Given this list of marker genes TGIF1, ZNF165, MRPL28, IRF7, DCUN1D2, SNAP91, PRG2, PIM3, STAR, CLK1, PCDHGA8, NR4A1, DIPK1B, EZH2, MIA2, CT83, PMAIP1, MAPK8IP1, MNT, STATH, IFIT3 (interferon induced protein with tetratricopeptide repeats 3), TP53INP2, SUN3, PPP4R1L, WDR19, LINC02112, PMP22, NFAT5, HOMER1, LINC00485, RGS2, ZCCHC14, MZF1-AS1, MYEF2, NOS3, LINC02537, TENT4A, NACA2, NOL12, LARP1B, H4C6, ZC3H8, KDM6B, THSD4, CXCL10, PELI1, LINC-PINT, GNL3L (NCBI Gene Id 54552), HTN3, TP53BP2, DNAJC27, MX1, CCNA1, GJB6, IRAK2, PDE4B, NIPAL1, NFKBID (NFKB inhibitor delta), MEX3B, FOXO3, RNF133, TRAF1, NIPA1, SLC25A33, CREB5, MAFK, ISG15, IFNB1, NR4A2, HCAR3 (hydroxycarboxylic acid receptor 3), IFIT2, TNF, ZC3H12C, MIR155HG, GCKR, EIF2AK3, GFOD1, ERRFI1, POLRMTP1, CSRNP2, OSM, PURB, NEURL3, CCDC134, NEBL-AS1, TBC1D21, CDRT15L2 (NCBI Gene Id 256223), C11orf96, B3GNT5, PTGER4, RNF19A, INSL3, ZNF620, PTGS2, MPZL1, GRIN2B, DNAJB1, CREBRF, CSRNP1, SPMIP1, GEM, CDR1, CLK4, MXD1, FNBP4, USP6NL-AS1, SLC22A4 (solute carrier family 22 member 4), SFRP5, RAB11FIP1, GPR32, SIRT1, FBXO34, RSPH9, TMEM217, RHOB, TPSD1, MAP3K20-AS1, HUS1B, IVNS1ABP, PATL2, FGF9, SSBP3-AS1 (NCBI Gene Id 619518), FAM200A, WFDC3, PCYT1B, SPTBN4, CREM, PLPPR4, CAMKK1, MAK, MIR22HG, GADD45B, EFNB2, ABO, BTBD19, MFAP4, CLCA1, TMEM212, SAMD5, DDX59, CFAP61, ABL2, DUBR, DENND4A (DENN domain containing 4A), NR4A3, CLDN10, HOXB13, PHF13, KBTBD8, GPLD1, MAT2A, IRS2, DRC3, AREG, PPP2R3B, MRGPRX2, PCDHAC2, IRF1, NAMPT (NCBI Gene Id 10135), SLC19A2, SCML1, GK, CREB3L3, RIMKLB, METRNL, DOP1A, TAMALIN, FAM9C, TTC32, ANKRD40CL, CSNK1D, AGAP2 (ArfGAP with GTPase domain, ankyrin repeat and PH domain 2), ZNF157, ZBTB43, KCTD5, ETV3, IFIT1, ZNF711, here is a description of the gene set: Genes down-regulated in comparison of control conventional dendritic cells (cDC) at 0 h versus cDCs infected with Newcastle disease virus (NDV) at 2 h. Human Gene Set: GSE18791_CTRL_VS_NEWCASTLE_VIRUS_DC_2H_DN from publication Zaslavsky E, Hershberg U, Seto J, Pham AM, Marquez S, Duke JL, Wetmur JG, Tenoever BR, Sealfon SC, Kleinstein SH (PMID 20164420) studied in species Homo sapiens The dendritic cell (DC) is a master regulator of immune responses. Pathogenic viruses subvert normal immune function in DCs through the expression of immune antagonists. Understanding how these antagonists interact with the host immune system requires knowledge of the underlying genetic regulatory network that operates during an uninhibited antiviral response. In order to isolate and identify this network, we studied DCs infected with Newcastle Disease Virus (NDV), which is able to stimulate innate immunity and DC maturation through activation of RIG-I signaling, but lacks the ability to evade the human interferon response. To analyze this experimental model, we developed a new approach integrating genome-wide expression kinetics and time-dependent promoter analysis. We found that the genetic program underlying the antiviral cell state transition during the first 18-hours post-infection could be explained by a single regulatory network. Gene expression changes were driven by a step-wise multi-factor cascading control mechanism, where the specific transcription factors controlling expression changed over time. Within this network, most individual genes are regulated by multiple factors, indicating robustness against virus-encoded immune evasion genes. In addition to effectively recapitulating current biological knowledge, we predicted, and validated experimentally, antiviral roles for several novel transcription factors. More generally, our results show how a genetic program can be temporally controlled through a single regulatory network to achieve the large-scale genetic reprogramming characteristic of cell state transitions.